Given this list of marker genes Glrb, Glra1, Slc6a9, Slc6a5, Slc7a10, here is a description of the gene set: studied in species Mus musculus Mouse Gene Set: GOBP_SYNAPTIC_TRANSMISSION_GLYCINERGIC The vesicular release of glycine from a presynapse, across a chemical synapse, the subsequent activation of glycine receptors at the postsynapse of a target cell (neuron, muscle, or secretory cell) and the effects of this activation on the postsynaptic membrane potential and ionic composition of the postsynaptic cytosol. This process encompasses both spontaneous and evoked release of neurotransmitter and all parts of synaptic vesicle exocytosis. Evoked transmission starts with the arrival of an action potential at the presynapse.